Given this list of marker genes Epcip, Trak1, Mef2a, Kat2a, Bhlha15, Tspan4, Msto1, Atcay, Pkd1, Ogt, Mapt, Cluh (NCBI Gene Id 74148), Tspan9, Slc4a5 (solute carrier family 4, sodium bicarbonate cotransporter, member 5), Mfn2, Dynll1, Mtm1, S2bpcox16, Armc1, Mfn1, Hap1 (huntingtin-associated protein 1), Dnm1l, Trak2, Synj2bp, Kif5b, Lrrk2, Myo19, Opa1, here is a description of the gene set: Any process that establishes the spatial arrangement of mitochondria between and within cells. Mouse Gene Set: GOBP_MITOCHONDRION_DISTRIBUTION studied in species Mus musculus